Given this list of marker genes DMP1, L1TD1, COA8, PTCH1, MFSD3, SH2D4B (NCBI Gene Id 407974), CPSF2, ICE2, GZMH, RDH10, ADD2, SNHG14, DMC1, MBP, KCNE4, NTRK2, STK33, TMA16, SLC25A4, C14orf39, IGHG1 (NCBI Gene Id 3500), IGKC, TSPAN11, TTC39B, MFSD4A, MEI4 (meiotic double-stranded break formation protein 4), SERPINA7 (serpin family A member 7), SCG5, IGFBP5, THSD4, CAGE1, RIC3, TRAM2, SCN2A, ZC3H13, GLI2, PTPRS, ADAM18, ADAMTSL5, PENK, MYB, CLEC2D, NEBL, MS4A1, MPZL2, SPATA9, RELCH, RAB22A, CCL22, ELAVL1, TECPR1, SLC1A3, NMNAT1, TNFRSF19, ALAS2, WNT9B, KNG1, TRPC1, HNF4G, CCR9, REG3G, ELAPOR1, IRS3P, NME7, VN1R5, IL11, LEPR, RERG, DUSP15, FAM110B, BCHE, MAP7, GPR174, SPON1, ABHD8, ZFP2, ALDH1A3, GRIA2, RBPJL, BDKRB2, TNMD, SFRP1, RADIL, SLC26A3, MIR23A, G6PD, SFSWAP, BRINP3, GLCE, TRIM5, TMEM100, CRIPTO, REG1A, PTHLH, WIF1, DDX23, GALR2, BCAS3, SPOCK1, SCARA5, SHISAL2B, DPH2, GDF10, NOG, AGBL4, AQR, SLCO4A1, SRGAP2, HSPA1A (heat shock protein family A (Hsp70) member 1A), BMP7, GIGYF2, EPHA3, TNFRSF9, TRPC3, FOXD1, SLC28A3, FRZB, BRWD3, PCSK5, ATP1A4, CTDSP2, PRTN3, CADM2, SUMF2, MASP1, DHCR24, C1QTNF7, SPIC, HSD11B1, SERPINB5, ARHGEF12, LCA5, TSPAN32, HEMGN, TCAIM, TMEM107, COL10A1, ZNF235, ARRDC4, NSG1, DUSP5, ST8SIA2, RELN, PCYOX1L (prenylcysteine oxidase 1 like, NCBI Gene Id 78991), BST1, PTGER3, SLC29A2, GLOD5, RET, here is a description of the gene set: from publication Yauch RL, Gould SE, Scales SJ, Tang T, Tian H, Ahn CP, Marshall D, Fu L, Januario T, Kallop D, Nannini-Pepe M, Kotkow K, Marsters JC, Rubin LL, de Sauvage FJ (PMID 18754008) Human Gene Set: YAUCH_HEDGEHOG_SIGNALING_PARACRINE_UP Ligand-dependent activation of the hedgehog (Hh) signalling pathway has been associated with tumorigenesis in a number of human tissues. Here we show that, although previous reports have described a cell-autonomous role for Hh signalling in these tumours, Hh ligands fail to activate signalling in tumour epithelial cells. In contrast, our data support ligand-dependent activation of the Hh pathway in the stromal microenvironment. Specific inhibition of Hh signalling using small molecule inhibitors, a neutralizing anti-Hh antibody or genetic deletion of smoothened (Smo) in the mouse stroma results in growth inhibition in xenograft tumour models. Taken together, these studies demonstrate a paracrine requirement for Hh ligand signalling in the tumorigenesis of Hh-expressing cancers and have important implications for the development of Hh pathway antagonists in cancer. Genes up-regulated in mouse stroma of pancreatic adenocarcinoma zenografts after treatment with HhAntag, a hedgehog (Hh) pathway inhibitor. species: Mus musculus